Given this list of marker genes Anxa11, Kng2, Bmp4, Tll2, Adamts16, Crlf3, Sftpd, Cripto (cripto, EGF-CFC family member), Insl5, Cd209d, Dhh, S100z, Adamdec1, Prl3a1, Il36rn, Prl7c1 (NCBI Gene Id 67505), Il10, Wnt16, Inhbc, Il1f10, Brinp3, Bdnf, Serpinb11, Cspg4, Crnn, Il12b, Clec5a, Prl8a1, Vegfc, Thpo, Clec4n, Csf3, Fgfbp3 (NCBI Gene Id 72514), Fgf15, Loxl4, Muc1, Adamts4, Muc5b, Rptn, Tnfsf11, Prl, Wnt7a, Cd109, Ogfod1 (NCBI Gene Id 338347), Gdf2, Prol1, Ccl25, S100a14, Adamts18, Mmp15, Mmp25, Elfn1, Tgfb3, Lgals9, Insl6, Cstdc2, Mmp1b, Tgm2, Serpina3g, Angptl4, S100a8, Serpina3f, Mmp2, Hyal3, Ifna12, Igf2, Egln3, Il9, Xcl1, Clec4b1, F7, Megf9, Wnt11, Pf4 (platelet factor 4), Ctsw, Nrtn, Wfikkn1, Adamts13 (ADAM metallopeptidase with thrombospondin type 1 motif 13), Ifnz, Tchhl1, S100a7a, Prl7a2, Cstdc6, Cxcl12, Tnfsf14, Ifne, F13b, Kng1, Reg1, Serpinb6d, Ereg, Serpina1d, Hcfc1, Hrg, Gm13271, P4htm, Gm13277, Adam26a, Adamtsl1, Adamts6, Wnt3, Clec1a, Gdf3, Adam28, Sema3e, Plxnc1, Sema4b, Serpina3n, Adamtsl5, Ccl17, Il11, Adam11, Serpina11, Fgf8, Lman1l, Inhba, Reg3b, Cx3cl1, Wfikkn2, Vegfd, Stfa1, Il13, Chrdl2, Hgfac, Lgals3, Cxcl1, C1qtnf4, Anxa8, S100a2, Clec2h, C1qtnf2 (C1q and tumor necrosis factor related protein 2), Sema6b, Reg3g, Inhbe, Il24, Wnt6, Hyal2, Cxcl3 (NCBI Gene Id 330122), Wnt2, Wnt9a, Serpinc1, Il22 (interleukin 22), Tnfsf4, Bmp2, Cxcl14, Muc4, Fgf23, Try4, Tnfsf12, Ccl1, Il19, Hpse2, Adam21, Ccl5 (C-C motif chemokine ligand 5), Spinkl, Cxcl11, Cd209a (NCBI Gene Id 170786), Sema5a, Gdf11, Ifna15, Mmp10, Hyal1, Ctsl, Prss3 (serine protease 3), Serpinb6c, Htra1, Cstdc1, Inha, Stfa2l1, Mdk, Muc21, Anxa5, Reg3a, Ngf, Serpina3a, Tgm4, C1qtnf12, Try10, Adamts20, Ifna11, Adam15, Adam12, Timp2, Ccl8, Ifnab, Tnfsf8, Hcfc2, Angpt1, Igf1, Il23a, Cfc1 (cryptic, EGF-CFC family member 1), Bmp8b, Adamts17, Fgf10, Tnfsf18, Sdc1, Lgals12, Tnfsf15, Sdc2, Fam20c, Angptl7, Adamtsl2, Adam1a, Hyal6, Sulf1, Cst13, Il5, Sema3b, Ccl19, Tgm6, Prl3d1, Wnt10b, Cts7, Plxna2, Egfl6, Serpina1f, Tgfb2, Serpina3c, Fgf4, Adam17, Serpinb1a, Serpinb9e, Angptl1, Wnt9b (wingless-type MMTV integration site family, member 9B), Prl2c1, Ambp, C1ql2, Csf2, Fstl3, Anxa13, A2m, Fgf13, Fgf14, Amh, Ccl24, Tgm3, Adamts5, Wnt8b, Clec4a4, Clec2i, Mmp24, Tmprss15, Serpina1a, Prl3b1, Ifng, Serpinb1b, Pdgfb, Ngly1, C1qtnf3, Prl2a1, Mmp19, Il1rn, Tchh (trichohyalin), Serpine3, Ccl21b, Adam30, Epgn, C1qtnf6, Adamts12, P4ha2, Gm13276, Il34, Clec2g, Ctsg (NCBI Gene Id 13035), Mst1, Muc16, Lgals8, Serpinb9f, Gdf1, Agt (NCBI Gene Id 11606), Tnfsf9, Astl, Nrg2, Frem3, Serpinf1, Plxdc1, Chrdl1, Cstl1, Inhbb, Gm5409, Pik3ip1, Wnt1, Pzp, F12, Anxa2, Gm13288, Csta2, Flg2, Htra4, Cbln4, Serpina3m, Tgm5, Mmp3, Sftpc, C1qa, Tgfb1, Tpbpa, Ccl9 (C-C motif chemokine ligand 9), Sema3f, Serpina3b, Sema3d, Adam20, Cspg5 (chondroitin sulfate proteoglycan 5), Elane, Ccl28, Tll1, Serpina10, Pspn, S100a6, Clec12a, Prl8a2, Ifna2, Prl8a8, Cst7, Hrnr, Fgf21, Pappa, Cxcl10, Pcsk6, S100a9, S100a3, Elfn2, Bmp15, Adam26b, Muc15, Mmp16, BC051665, Ctsk, Sema3g, Adam5, Serpinb6a, Tnfsf13b, Pdgfc, Adamts14, Serpini2, Cela3b, Gm4787, Sfrp1, Clec11a, Hpx, Gdf6, Hbegf, Mmp12, Adam29, Csta1, Clec4d, Parm1, Mmp23, Plxdc2, Adamts7, Ntf3, S100a13, Gm13278, Clec4a1, Ifna7, Ifna14, Serpinb6b, Clcf1, Eda, Nrg1, Adamts1, Fgf18, Serpine2, Sema6a, Sema4g, Adam25, Sulf2, Ctss, Plxna1, C1ql4, Egln2, Sftpb, Anxa4, Megf6, C1ql1, F2, Flt3l, Tnfsfm13, Mmp7, Crhbp, Il17b, Plat, Plxna3, Itih1, Ccl7, Gpc6, Bmp6, Wnt7b, Clec9a, Gpc2, Lgals2, Timp1, Timp3, Cela1, Gm13290, Prl2b1, Il17d, Cst11, Serpina3k, Cxcl2, Gpc1, P3h1, Ccl6, Bmp1, Serpine1, Timp4, Prl4a1, Ltb, Cbln1, Adam1b, Epo, Clec4a3, Serpinb9, S100a5, Fgf20, Ctf2, Muc13, Shh, Wnt10a, Egf, Anxa6, Ccl11, Prl7d1, P4ha3, Cbln3, Wnt4, Prl3c1, Adam7, Cts3, S100g, Muc2, Kazald1, Pcsk5, Ifna4, Mstn, Il16, Wnt3a, Serpinb10, Adam3, Adamts2, Il7, Cela2a, Cxcl15, Adam9, Prl2c5, Clec14a, Clec7a, St14, Ctsc, Adamts10, Hhip, Pamr1, Try5, Ctsz, Cst12, Serping1, Gdnf, Il6, C1qtnf9, Gm5347, Gm13272, Adam39, Ccl26, Vwc2, Bmp3, C1qtnf7, Prss1 (serine protease 1 (trypsin 1)), Prss3l, Fasl, Ptn (pleiotrophin), Sfta2, Adam8, Il20, Muc20, Ifnb1, Ccl22, Kitl, Gdf5, Erfe, Fgf5, Flg, Sema4c, Gh, Gdf7, Serpinh1, Hyal5, S100a11, Prss12, Cntf, Loxl1, Cd209b, Adam10, Ifna9, Cst9, Serpina7 (serine (or cysteine) peptidase inhibitor, clade A (alpha-1 antiproteinase, antitrypsin), member 7), Clec18a, Serpina5, Ccl27a, Ctsr, Clec2j, Wnt5b, Bmp10, Mep1a, Anxa7, Ntf5, Serpinb7, Mmp1a, Reg3d, Serpinb3a, Gm13279, Gpc3, Sema7a, Gdf9, Itih5, Itln1, Cst3, Ctsd, Ppbp, Bmp8a, Nrg4, Gm13287, Muc17, Cstdc5, Clec2l, Adamtsl3, Plxna4, Serpinb3d, Fgf1 (fibroblast growth factor 1), Ccl21a, Ccbe1, Ctsh, Ctf1, Gpc5, Adam22, Mmp21, Serpinf2, Lif, Ism2 (isthmin 2), Serpina6 (serine (or cysteine) peptidase inhibitor, clade A, member 6), Serpinb5, Adam6a (NCBI Gene Id 238406), Ogfod2, Fgf17, Crlf1, Frzb (frizzled-related protein), C1qtnf5, 1810010H24Rik (NCBI Gene Id 69066), S100a10 (NCBI Gene Id 99776), Il3, Artn (NCBI Gene Id 11876), Lep, Il2, Insl3, Ifna6, Serpinb8, Prl5a1, Adamts9, Mmp14, Gdf10, Chrd, Reg4, Hpse, Sfrp2, Clec4e, Fgf9, Ifna5, Il17f, Gm13285, Serpinb3c, Ctso, Cxcl5, Colec12 (NCBI Gene Id 225157), Sema3a, Lgalsl, Egln1, Tgm7, Cstb, Masp2, C1ql3, Ccl4, Serpina1b (serine (or cysteine) preptidase inhibitor, clade A, member 1B), Cela3a, Wnt5a, AI182371, Il15, Mmp28, Angptl2 (angiopoietin-like 2), Csf1, Zpld2, Brinp2, Ctsll3, Il18 (interleukin 18), Sema5b, Clec2d, Ctsq, Clec12b, S100a16, Megf8, Plg, Serpini1, Sema6c, Fst, Fstl1, Colec11, Htra3, Megf11, Sema6d, A2ml1, Areg (NCBI Gene Id 11839), Gdf15, Frem2, Prl7a1, Btc, Gm13283, Fgf22, Prl2c3, C1qc, Slpi, Mmp17, Lgals7, Mmp8, Serpinb9c, Serpinb9g, Gm13275, Tpbpb, Vegfb, Mmp13, F10, Bmp7, Fgf3 (fibroblast growth factor 3), Cts6, Ins2, Clec4g, Hyal4, F9, Adam33, Egfl7, Adam18, Adam32, Il36b, Il36g, Sema4a, Ovgp1, Megf10, Adamts15, Sftpa1, Serpina9, Cxcl13, Pdgfa, Il1b, Egfl8, Ctsa, Lta, Angptl3 (NCBI Gene Id 30924), Wnt8a, Pappa2, Ctsm, Ins1, Vegfa, Anxa9, Fgf7, Colec10, Vwc2l, Prl3d2, Fam20a, Bmp5, Fcna, Tgm1, Adam6b, Angpt2, Nodal, Ctsf, Cst6, Plxnd1, Adamts19, Scube1, Plxnb3, Clec3a, Ky, Grifin, Plau, Osm, Mmp20, Lman1, Mbl2, Prl8a6, C1qtnf1, Habp2, Sema4d, Scube3, Serpinb9b, Cxcl9, Anxa3, Clec4b2, Mmp27, Plod3, Fgf2, Fcnb, Loxl2, Lefty1, Ifnk, Ccl20, Angptl6, P3h2, Fgfbp1, Prss1l, Fam20b, Hgf, Mep1b, Muc5ac, Pgf, Mbl1, Serpina12, Prl2c2, Mmp11, Serpinb1c, Il1a, Nrg3, Lox (lysyl oxidase), Scube2, Serpina1c, Adam4, Ccl2, Ctse, Mug2, Grem1, Lgals4, Sema4f, Cts8, Tnf, Gm13289 (NCBI Gene Id 545647), Adamtsl4, Il17c, Wnt2b, Anxa1, Adam23, Plxnb2, Reg2, Ccl27al, Serpind1, Sfrp4, Adam24, Pdgfd, Adam19, Ebi3, Adamts3, S100a1, Cbln2, Spam1, Masp1, Lgals1, F13a1, Tpo, Prl3d3, S100a4, Clec4f, Clec2e, Sdc4, Il4, Serpinb2, Emcn, Anxa10, Prl6a1, Ism1, Serpinb9d, Itih3, Clec10a, Muc6, Clec1b, Serpinb12, Mucl1, Sema3c, Ctsb, Itih4, Fgf11, Clec4a2, Cst8, Lefty2, Prl7b1, Wif1, Serpina1e, Muc19, Ihh, Clec3b, Fgf12, Loxl3, Stfa3, Prl8a9, Serpinb3b, Ctsj, Tnfsf13, Ifna1, Il36a, Itih2, Cstdc4, Il17a, Gm5849, Ifna16, Sfrp5, Ccl3, Fgf6 (fibroblast growth factor 6), Fgf16, Adam34, Cstdc3, Il12a, Adam2, Frem1, Cpn2, Csta3, C1qb, Plod2, Plod1, Adamts8, S100b, Ifna13, Il25, Tnfsf10, Gpc4, Cst5, Angpt4, Stfa2, Prss2, Ccl12, P4ha1, P3h3, Serpinb13, Mmp9, Tgfa, Plxnb1, Sdc3, here is a description of the gene set: Ensemble of genes encoding ECM-associated proteins including ECM-affilaited proteins, ECM regulators and secreted factors from publication Naba A, Clauser KR, Hoersch S, Liu H, Carr SA, Hynes RO (PMID 22159717) studied in species Mus musculus One hallmark of ECM proteins is their domain-based structure. Exploiting this characteristic, we established a list of diagnostic InterPro domains commonly found in ECM proteins. We know that some of the domains used to select positively for ECM proteins are also found in transmembrane receptors and proteins involved in cell adhesion (growth factor receptors, integrins, etc) that do not belong to the ECM. These families of proteins also display a subset of specific domains and transmembrane domains incompatible with definition as Mouse Gene Set: NABA_MATRISOME_ASSOCIATED